Given this list of marker genes DEDD, SNRNP27, ZNF143, ATG13, CTNNAL1, C1D, INPP5E, KRBOX4, DNAJA2, ZNF451, SUSD6, SLC12A4, PRSS12, NOP14, FLI1, ATP9B, GLIPR2, ADM, CDC42EP2, SEPHS2, ITIH4, LCAT, UROS, CAPN2 (calpain 2), BTN3A1, MYO1B, TMEM115, CASP4, STOML1, SLC31A2, BPGM, CDIPT, PHF11, CDA (cytidine deaminase), CHMP1B, CSTF2, EGR3, KLF5, PDGFRA (platelet derived growth factor receptor alpha), NT5C2, HLX, SMAD7, HAS2, TMCO6, PTPN11, EIF2S1, HAX1, ATP6V1C1, HSPA12A (NCBI Gene Id 9893), TWF2, ATG16L2, EDC4, SLCO1A2, SNAPC2, ACKR4, SP100, TRIP10, ZFX, TSC1 (TSC complex subunit 1), CLK3, RFXANK, HOXC5, ARHGAP32, SDCBP, TEAD3, HERC3, LPCAT4, MAN2A2, KIAA0930, FILIP1L, JUN, ZNF33A, UGP2, VAMP4, RNH1, ACP2, TAF2, SYNJ1, KIF3A, ITGA11, GSTA4, SLC9A1, PTGS1, MT1B, CNPY3, NUAK1, RNF185, TOM1, LGALS4, ADD3, PDLIM1, PSPHP1, FADS3, TNFRSF10B, HIPK3, RAC2, MASP2, CUL3, DELE1, STX6, G0S2, RNF41, PTPRG, NMT1, BTG1, CNTNAP1, TNK2, CYBRD1, PNMA1, ARHGEF2, RAMP2, TSC22D3, GPC1, CYBA, IFNGR1 (NCBI Gene Id 3459), EFTUD2, TLK1, CEBPB, PARP4, UMOD, CD46, GEMIN2, TAF11 (TATA-box binding protein associated factor 11), STEAP2-AS1, CDC40, ZNF317, KLF10, VEZF1, AIRE, WASHC2A, CDKN1A, PPP3CB, BBC3, CSRNP2, IFNGR2, EIF4A1, SRRD, FNTA, TGIF1, SESN1, CSNK1G3, PRKG1, TESK1, TCEAL1, FZD2, HSPB3, MAP3K7CL, YPEL1, UBE2D1, DDX52, GALNS, TXNRD1 (NCBI Gene Id 7296), CYP1B1, SSNA1, CASP3, YBX3, EFR3A, UBE2B, MAML1, WDR83OS, EHHADH, ELF1, RABEP1, DYRK3, CCNG2, RUSF1, MMP19, SDHB (succinate dehydrogenase complex iron sulfur subunit B), PNN, GNAI1, KCNMB1, MED13, RRAS, TAF9, BCL6, NRG1, KHNYN, VEGFC, IL1R1, BCS1L, PAIP1 (NCBI Gene Id 10605), RUNX1, TFPI2, MYF6, STOM, HIF1A, MRPL40, KALRN, EBAG9, CELF1, BNC1, TANK, GRSF1, TAF7, HBP1, ACVR1, MAP2K5, ERAL1, CD248, CDC7, PNPLA4, MLLT11, STAT1, GADD45A, AGXT, NRP1, PNP, PTPRT, DUSP2, SERPING1, WTAP, HMGN4, SLC35A1, EIF3G (NCBI Gene Id 9606), FERMT2, MAP4K5, CSF1, MKRN1, TNFAIP6, here is a description of the gene set: Human Gene Set: WANG_CISPLATIN_RESPONSE_AND_XPC_DN Genes down-regulated in fibroblasts with defective XPC in response to cisplatin. studied in species Homo sapiens XPC is an important DNA damage recognition protein involved in DNA nucleotide excision repair. We have studied the role of the XPC protein in cisplatin treatment-mediated cell cycle regulation. Through the comparison of microarray data obtained from human normal fibroblasts and two individual XPC-defective cell lines, genes were identified as XPC-responsive genes in the cisplatin treatment (with a minimal 1.5-fold change) and 297 of these genes were further mapped to biological pathways and gene ontologies. The cell cycle and cell proliferation-related genes were the most affected genes by the XPC defect in the cisplatin treatment. Many other cellular function genes were also affected by the XPC defect in the treatment. Western blot hybridization results revealed that the XPC defect reduced the p53 responses to the cisplatin treatment. The ability to activate caspase-3 was also attenuated in the XPC cells with the treatment. These results suggest that the XPC protein plays a critical role in initiating the cisplatin DNA damaging treatment-mediated signal transduction process, resulting in activation of the p53 pathway and cell cycle arrest that allow DNA repair and apoptosis to take place. These results reveal an important role of the XPC protein in the cancer prevention. from publication Wang G, Chuang L, Zhang X, Colton S, Dombkowski A, Reiners J, Diakiw A, Xu XS (PMID 15107491)